The following is a description of a gene set: Catalysis of the reaction: a 1-phosphatidyl-1D-myo-inositol 4-phosphate + ATP = a 1-phosphatidyl-1D-myo-inositol 4,5-bisphosphate + ADP + H+. species: Mus musculus Mouse Gene Set: GOMF_1_PHOSPHATIDYLINOSITOL_4_PHOSPHATE_5_KINASE_ACTIVITY, and this is the list of marker genes: Pip4k2b, Pip5k1b, Pip4k2a, Pip5kl1, Pikfyve, Pip4k2c, Pip5k1a, Pip5k1c